Given this list of marker genes Gng7, Gng11, Gng10, Aqp1, Gngt1, Aqp4, Prkar2b, Gng8, Prkar1b, Gng5, Rab11fip2, Avpr2, Gnb3, Gngt2, Prkaca, Gng3, Gng4, Gnb5, Prkacb, Rab11a, Gnb2, Avp, here is a description of the gene set: part of: Aquaporin-mediated transport electronically inferred by orthology from the curated human pathway Reactome Pathway: Vasopressin regulates renal water homeostasis via Aquaporins studied in species Mus musculus This event has been computationally inferred from an event that has been demonstrated in another species.<p>The inference is based on the homology mapping from PANTHER. Briefly, reactions for which all involved PhysicalEntities (in input, output and catalyst) have a mapped orthologue/paralogue (for complexes at least 75% of components must have a mapping) are inferred to the other species.